The following is a description of a gene set: studied in species Homo sapiens Human Gene Set: KEGG_MEDICUS_REFERENCE_CLASSICAL_PATHWAY_OF_COMPLEMENT_CASCADE_C4_C2_TO_C3_CONVERTASE_FORMATION Classical pathway of complement cascade, C4/C2 to C3 convertase formation. Pathway ID: N01487. Pathway type: Reference. Pathway class: nt06513 Complement cascade. Pathway Definition from KEGG: -- ((C1QA,C1QB,C1QC)+C1R+C1S) -> -> (C4b+C2a), and this is the list of marker genes: C4A, C2, C1R (NCBI Gene Id 791254), C1QC, C1QA, C1QB, C1S, C4B